Given this list of marker genes Pnkd, Cry2, Cry1, Cacnb4, Inhbb, Rph3al, Glul, Lin7a, Pla2g1b, Scn11a, Prl6a1, Mecp2, Nrxn2, Adora2b, Rac2, Myo5a, Inha, Car2, Wdr41, Slc30a8, Ctbp2, Adcyap1, Hck, Mpc2, Bglap, Rhot1, Uprt, Rufy4, F2r, Nmur2, Rab8a, Tbx3, Pask, Fcgr3, Hyal3, Ces1g, Midn, Gpr68, Mctp2, Septin1, Snap47, Kcnh1 (NCBI Gene Id 16510), Kcnma1, Nell2, Cckbr, Pla2g12b, Olfm2, Lyst, Nagpa, Nr3c1, Tlr4, Cacna1d (NCBI Gene Id 97919), Orai1, Rplp0, Abat, Kiss1r, Ier3ip1, Tcf7l2, Myo5b, Tmem167, Lrp5 (low density lipoprotein receptor-related protein 5), Frmd4a, Traf3ip2, Tnfaip2, Fgg, Cbl, Retn (NCBI Gene Id 65097), Atg5 (NCBI Gene Id 97669), Foxf1, Vegfa, Ces1a, Tvp23b, Cacna1h, Rapgef4, Npy2r, Chrna4, Cacna1c (NCBI Gene Id 619317), Mir130a, Mrgprb1, Prl7a2, Mup4, Slc51b, Slc44a4, Npff, Prickle1, Ppid, Snap29, Kcnc3, Prkar1a, Syt8, Myom1, Mif, Rab8b, Csf2, Crhr1, Stard10, Exoc3, Ppia (peptidylprolyl isomerase A), Dnm1l, Syngr1, Oprk1, Hmox1, Abcc8, Abcb11, Rcn3, Psap, Sybu, Stx17, Sct, Arhgap17, Nppc, Cltrn, Cd200, Tspo, Slc30a1, Nr4a3, Syt4, Asic1, Kcnj8, Slc12a2, Syt11, Vamp8, Ano1, Tardbp, Cxcl12, Rhbdd1, Cyp4a10, Oga, Sstr4, Grin2b, Igfbp3, Rab34 (RAB34, member RAS oncogene family), Psmd9, Ccr1l1, Exph5, Rab11fip3, Agr2, Pck2, Anxa5, S100a10, Ncoa1, Cavin1, P2ry12, F2rl1, Itgb2l, Kcnk2, Ins1, Pdx1, Hap1, Napb, Tnfrsf11a, Stxbp1, Syt1, Syt9, Nr1h2, Acsl4, Clnk, Sytl2, Pick1, Snx10, Cacna1i, Prl3d2, Mtnr1a, Gnai2, Prl3c1, Idua, Sec24a, Stx19, Oc90, Edn2, Wnt7a, Smcr8, Rab33b, Slc9b2, Spp1, Nppa, Brsk2, Sphk2, Ccr2, Crhr2, Ralb, Mup11, C1qtnf3, Tph1, Uts2, Agtr1a, Gck, Rasl10b, Slc8b1, Mertk, Mfn2, Cplx2, Neo1, Stx3, Cpt1a, Anxa3, Ppp3cb, Ngf, Syde1, Prkn, Cartpt, Hip1r, Ddr1, Lrp1, Nr1h3, Vps4b (vacuolar protein sorting 4B), Ahi1, Itpr1, Il12a, Rab14, Syt10, Tgfb1, Rims2, Nrxn1, Nkd2, Lin7b, Fes (NCBI Gene Id 14159), Bloc1s6, Sytl4, Nlrp5, Il4ra, Cela2a, Gnas, Cplx1, Fgb, Gpat4, Fosl2, Arl8b, Steap2, Cyp2j5, Ghsr, mt-Co2, Abr, Btk, Fcer1a, Lin7c, Tmem132a, Vdr, Tmem167b, Lhcgr, Rhbdf1, Hmga1, Rab11fip1, Fcer1g, Arf1, Il13ra2, Lgals9, Vps4a (vacuolar protein sorting 4A), Nr1h4, Ptges, Bcl2l1, Foxl2, Doc2a, Nucb2, Mup2, Exoc5, P2rx1, Ap1m2, Grm2, Ccdc186, Rtn4, Trpc1, Stam, Trpv1 (NCBI Gene Id 22366), Mon1a, Ncam1, Pou5f1, Aqp4, Rab11fip5, Ggcx, Exoc2, Bcr, Atg7, Cd177, Rab3b, Syp, Plcd1, Aqp1, Pfn2, Myh10, Vamp2, Sucnr1, Gcg, Hcar2, Tlr2, Nlrp6, Htr2a, Myo6, Stxbp5, Abcb1a, Tbc1d1, Sstr5, Cd2ap, C9orf72, Prrt2, Prl3b1, Kcna2 (NCBI Gene Id 16490), Slc2a2, Gprc6a, Nherf1, Snord33 (small nucleolar RNA, C/D box 33), Adam8, Nrxn3, Alox5, Myo18a, Fgf23, Pla2g2e, Cadps, Igf1, Tacr2, Serp1, Foxd1, Prkce, Tmem79, Csn3, Ang, Kcnq2, Slc1a5, Fgfr1, Mical3, Pla2g6, Pfkl, Adam9, Gpr119, Sphk1, Htr7 (5-hydroxytryptamine (serotonin) receptor 7), Mef2c, Or51e2, Chrm5 (NCBI Gene Id 278891), Zp3, Adra2a, Vps41, Abca12, Aimp1, Negr1, Htr2c, Prl, Pi4k2a, Idh2, Xlr4a, Anxa1, Snord34, Acsl3, Itsn1, Gper1, Pofut2, Fbxo45, Prl2c2, Pdzd11, Golph3l, Tacr1, Cdo1, Hgs, Lgals3, Vegfc, Oxct1, Ndufaf2, Rab11a, Wnk4, Slc29a1, Prl7c1, Cspg5, Exoc3l2, P2ry4, Ffar1, Kpna4, Prepl, Vsnl1 (visinin-like 1), Syt7, Sel1l, Ednra, Casr, Dgat1, Milr1, Psen1, Aqp5, Furin, Ica1, Casp1, Prkg1, Gpr151, Ucp2, Hmgn3, Gpr158, Adtrp, Cd84, Cadps2, Nckap1l, Snf8, Prkcq, Pip5k1c, Dpysl2, Exoc3l4, Sox4, Fmr1, Ykt6, Muc2, Erbb3, Abcc2, Serpine2, Wnk1, Srcin1, Cplx4, Itgb2, Il13, Sco1 (NCBI Gene Id 67104), Gnat1, Myc, Pcsk6, Osm, Apbb1, Doc2g, Pla2g4f, Lrrc8a, Park7, Lamp1, Brsk1, Gata3, Fgfr4, Stx1b, Mafa, Zfp384, Syt17, Tac4, Apln, Edn3, Pdpk1, Rab44, Pcp4, Snap23, Sncg (synuclein, gamma), Myh9, Nadk, Ap1g1, Tvp23a, Mttp, Gnptab, Bsg, Gdf9, Prl2b1, Stx4a, Cask, Slc9a4, Fgr, Prf1, Tprg1l (transformation related protein 63 regulated 1 like), B3glct, Ptprn, Abcc3, Hnf1a, Cd74, Grp, Epb41l1, Acvr2b, Trp73, Hk2, Gnao1, Sdc1, Usf2, Mup1, Isl1, Eny2, Pla2g2d, Prl2c3, Rap1a, Pafah1b1, Vps11 (VPS11, CORVET/HOPS core subunit), Nlgn2, Gpr15lg, Filip1l, Septin4, Mia3, Apba1, Fga, Pim3, Cd160, Akap5, D6Wsu163e, Arhgef7, Irs2, Ccl3, Atp5pf, Pex5l, Sirt3, Ghrhr, Dph3, Lat, Lypd10, Hrh2, Jak2, Ces1d (NCBI Gene Id 104158), Slc6a4, Crhbp, Tmf1, Pla2g4a, Snap91, Prl8a6, Agt, Txlna, S100a9, Braf, Hnf1b, Per2, Apbb3, Ildr2, Kcnc4, Slc26a6, Arfgef2, Sv2b, Stc1, Cd300a, Zbed6, Prl8a8, Tfr2, Prl8a1, Entpd1, Adcy8, Avpr1b, Rab21, Ada, Itgam, Dab2, Rptor, Rab7, Slc38a2, Copa, Exoc6b, Inhba, Egf, Foxo1, Ang5, Bdnf, Pla2g2a, Hps1, Rimbp2, Rab12, Srebf1, Nrg1, Ensa, Spx, Chrna7, Egfr (NCBI Gene Id 13649), Eipr1, Mlxipl, Kcnb1, Htr1b, Snord32a, Aacs, Prl7b1, Ptges2, Prkcg, Foxa2, Cklf, Tnfrsf1b, Syt6, Sirt6, Prl7a1, Gpr39, Ifnb1, Snx4, Nos1 (nitric oxide synthase 1, neuronal), Il11, Plek, Cnr1, Mctp1, Stx2, Gzmb, Ap1b1, Exoc4, Comp, Hnf4a, Stat5a, Mapk9, Gabbr1, M6pr, Exoc8, Ttn, Septin5, Map1lc3b, Sytl5, Chrm1, Eng, Ncs1, Sycn, Grxcr1, Cd38, Hmga2, Celsr2, Il4, Stxbp5l, Trpv6, Lat2, Corin, Slc18a1, P2ry1, Bdkrb2, Gnai1, Fam3a, Dgki, Hcrt, Adora3, Eif2ak3, F2, Lyn, Slc16a10, Tgfb3 (transforming growth factor, beta 3), Prl2a1, Golph3, Cplx3, Prkcb, Grik1, Cyp19a1, Pla2g12a, Slc51a, Ptprn2, F2rl2, Rap1b, Synj1, Washc5, Smad4, Rbm4, Umps, Madd (NCBI Gene Id 353087), Nisch, Cyp27b1, Pink1, Il6, Ffar2, Exoc1 (exocyst complex component 1), Cldn2, Prl7d1, Niban2, Ghrl, Htr6, Npy1r, Umod, Prl3d3, Cbarp, Ppard, Sv2a, Tsg101, Hrh3, Zbtb7b, Lmf1, Cyp4a31, Kcnj6, Fkbp1b, Rab9, Tspan18, Lif, Adipoq, Acvr1c, Sirt1, Il1b, Vamp3, Vps35, Trpa1, Pcsk1, Arfip1, Prl8a9, Slc38a3, Jagn1, Syt13, Pde8b, Tunar, P2rx2, Tifab, Hadh, Rims3, Krt20, Ap1s1, Ucn, Trarg1, Rab2b, Stxbp3, Pomc, Cyp51, Agtr2, Stx1a, Cftr, Ppfia3, Drd3, Slc18a3, Snap25, Unc13b, Rasgrp1, Napa, Micu3, Slc4a8, Rab31 (RAB31, member RAS oncogene family), Pax8, Avp, Cntf, Mip, Il1rapl1, Chuk, Rbp4, Ric1, Erbb4, Rala, Htr1d, Lepr, Atp9a (NCBI Gene Id 11981), Pclo, Ccnd1, Uqcc2, Rab25, Prl2c1, Fam3b, Pram1, Git2, Ptger3, Wipf3, Adora2a, Tmed10-ps, Pparg, Erp29, Malrd1, P2rx7, Gip, Clasp2, Nmu, Sergef, Drd4, Llgl1, Ptgs2, Rab26, Cbln4, Kiss1, Rap1gds1, Anxa2, Ccr1, Mical1, Chrnb2, Cyba, Gja1, Cyp4a32, Clcf1 (NCBI Gene Id 56708), Tiam1, Prkca, Kmo, Npr3, S100a8 (S100 calcium binding protein A8 (calgranulin A)), Gnaq, Efr3a, Mtnr1b, Sox11, Htr1a, Sptbn2, Grm8, Rab3c, Guca2b, Oprm1, P2ry2, Nr0b2, Tfap2b, Ceacam1, Vamp9, Rest, Slc22a16, Proca1, Syt5, Ins2, Unc13d, Dnajc1, Rab37, Mc4r, Il1a, Adam17, Atp7b, Stx11, Nsf, Tgm2, Zfp469, Clstn3, Myrip, Trim9, Slc6a9, Erc2, Mir410, Klf7, Spi1, Trappc11, Git1, Slc26a7, C2cd2l, Pnpla8, Baiap3, Fgf7, Nr1d1, Ren1, Rgcc, Kdm5b (NCBI Gene Id 98723), Ppt1, Stk39, Ighe, Trpv4, Aqp8, Ankrd1 (NCBI Gene Id 12907), Cyb5r4, Cdk5r2, Bloc1s3, Bmal1, Hcfc1, Adcy5, Bmp2, Svbp, Pdcd6ip, Washc1, Chrm3, Ces1c, Fzd4 (NCBI Gene Id 14366), Tcirg1, Crh, Gna11, Mmp7, Slc4a5, Unc13a, Fgf10, Vps13a, Blk, Irs1, Fam3d, Pla2g10, Pfkm, Rab11b, Scrn1, Rab40b, Nos2, Sytl1, Slc25a22, Cdk5, Tpcn2, Hps6, Mup3, Pik3c2a, Dynll1, Ptger4, Pikfyve, Ildr1, Rab3gap1, Ang2, Ucn2, Smpd3, Pak1, Gipr, Slc16a1, Tgfb2, Ptbp1, Prl4a1, Nr4a1, Rhbdf2, Maob, Gja5, Aqp9, Sdc4, Trim72, Cga, Doc2b, Syk, Camk2n1, Npsr1, Porcn, Neurog1, Npy5r, Scg5, Rab27a, Vamp1, Kcnj11, Osbp, Cwh43, Otof, Scrib, Gab2 (NCBI Gene Id 14389), Sncaip (NCBI Gene Id 71194), Acacb, Hmgcr, Ang6 (angiogenin, ribonuclease A family, member 6), Trh, Scnn1b, Rfx6, Abca1, Tmem38b, Ptgds, Grk2, Stim1, Ccl8, Grm7, Arfgap3, Ednrb, Bad, Stxbp2, Vgf, Lgi3, Scamp1, Pianp, Plcb1, Nkg7, Prlr, Unc13c, Cplane2, Abcg1, Ly6e, Fbn1, C1qtnf5, Myo1f, Gcgr, Ccn3, Copg1, Atp2a2, Med1, Ppfia2, Grik5, Dtnbp1, Rab3d, Stat5b (NCBI Gene Id 20851), Ccl5, Fcgr4, Avpr1a, Sidt2 (NCBI Gene Id 214598), Rab40c, Axl, Atp13a2, Tnfrsf1a, Kif5b, Arf6, Cad, Neurod1, Syt12, Sv2c, Slc16a2, Trpc4, Rab5a, Il1rn, Myt1, Pfkfb2, Nkx2-3 (NCBI Gene Id 18089), Tnfsf11, Pla2g3, Exoc6, Hif1a, Tango2, P3h1, Sirt4, Car9, Sdhd, Nmb, Syn1, Nkx3-1, Trem2, Xbp1, Mrgprx2 (NCBI Gene Id 243978), Ptgs1, Gipc1, Ghrh, Htr4, Map2k6, Agxt, Tff2, Steap3, Neurl1a, Anxa7, Mmp13, Scamp5, Kctd9, Ube2q1, Csn2, Slc18a2, Prl5a1 (NCBI Gene Id 74232), Snapin, Ang4, Pla2g2f, Xlr4b, Erc1, Xdh, Cbln1, Slc6a3, Ntsr1, Clasp1, Sdcbp, Efna5, Ep300 (NCBI Gene Id 328572), Tcp11, Kcnk1 (NCBI Gene Id 212682), Galr1, Ppp3ca, Rac1, Prl3d1, Tmed10, Sdf4, Ntrk2, Il12b, Acvr2a, Dvl1, Ccn2, Myb, Washc3, Chmp2a, Htt, Coro1a, Npy, Apoe, Prl3a1, Ces1e, Tyro3, Cckar, Bmp6, Drd2, Ecrg4, Vip, Osbpl2 (oxysterol binding protein-like 2), Comt, Rabgef1, Snx19 (NCBI Gene Id 74331), Enpp1, Chd7, Sri, Runx1, Fbxl20, Pla2g5, Creb1, Rab10, Snca, Lrrk2, C1qtnf1, Kcnn4, Pde1c, Tm7sf3, Ptpn23, Mir200a, Prl2c5, Ptpmt1, Nnat, C1qtnf12, Trpm5 (NCBI Gene Id 56843), Ppp1r9a, Smad2, Cck, Tmem63b, Mia2 (NCBI Gene Id 52890), Rab11fip2, Wnk3, Tango6, Tnf, Tmem63a, Llgl2, Camk2a, Raf1, Rhbdd3, Selenot, Map4k4, Exoc3l, Slc6a1, Rfx3, Glud1, Gal, Nme1, Epha5, A1cf, Abcb4, Oas2, Rab1a, Tspoap1, Ces1b, Rab27b, Pla2r1, Ces1h (NCBI Gene Id 75704), Syngr2, Rab3a, Ms4a2, Nlgn1, Cops5, Rims4, Fbln5, G6pc2, Hfe, Sfrp1, Kcnq1, Syn2, Prl8a2, Prss12 (NCBI Gene Id 19142, serine protease 12 neurotrypsin (motopsin)), Tac1, Prkaca, Cpe, Wls, Socs2, Npvf, Myo1g, Trpm2, Cel, Piwil4, Glp1r, Creb3l1, Cav1, Copg2, Ffar3, Kalrn, Pde3b, Chga, Pard6a, Prkd1, Rims1, Cacna1e (NCBI Gene Id 269133), Pla2g2c, Vps18, Sytl3, Ifng, Gpr27 (G protein-coupled receptor 27), Sacm1l, Cacna1b, Chrna3 (NCBI Gene Id 235388), Arrb1, Edn1, Abcc4, Fto, Notch1, Lypd11, Eqtn, Cacna1g, Oxt, Gpld1, Ltbp4, Pde4c, Birc5, Syt3 (NCBI Gene Id 20981), Kit, Ptafr, Cacna1a, Ncoa6, Aprt, Slc4a9, Gnaz, Ptprv (protein tyrosine phosphatase receptor type V), Syn3, Gata1, Kcnk9, Ace, Rsad2, Gata2, Mup5, Best1, Trpm4, Cdk16, Mcu, Snord35a, Tmem258, Ywhaz, Adora1, Exoc7, Nkx6-1 (NCBI Gene Id 18096), Syngr3, Rab15, Rph3a, Tmem184a, Gsdmd, Lep, Nf1, Foxb1, Selenom, Ptpn11, Ces1f, Stxbp4, Syt2 (NCBI Gene Id 96937), Ffar4, Rab13, Syt15, Atp2b2, Oxtr, Kcnq3, Cpb2, Chrna6, Ucn3, Ptgdr, Clock, Dio2, Alox12b, Tmed2 (NCBI Gene Id 76322), Capn10, Pld2, Bglap2 (bone gamma-carboxyglutamate protein 2), here is a description of the gene set: studied in species Mus musculus Mouse Gene Set: GOBP_SECRETION The controlled release of a substance by a cell or a tissue.